Given this list of marker genes Dusp1, Jun, Hspa1a, Fos, Hspa1b, Fosb, Zfp36, here is a description of the gene set: from publication Cui A, Huang T, Li S, Ma A, Pérez JL, Sander C, Keskin DB, Wu CJ, Fraenkel E, Hacohen N (PMID 38057668) Cytokines mediate cell-cell communication in the immune system and represent important therapeutic targets. A myriad of studies have highlighted their central role in immune function, yet we lack a global view of the cellular responses of each immune cell type to each cytokine. To address this gap, the authors created the Immune Dictionary, a compendium of single-cell transcriptomic profiles of more than 17 immune cell types in response to each of 86 cytokines (>1,400 cytokine-cell type combinations) in mouse lymph nodes in vivo. A cytokine-centric view of the dictionary revealed that most cytokines induce highly cell-type-specific responses. For example, the inflammatory cytokine interleukin-1β induces distinct gene programmes in almost every cell type. A cell-type-centric view of the dictionary identified more than 66 cytokine-driven cellular polarization states across immune cell types, including previously uncharacterized states such as an interleukin-18-induced polyfunctional natural killer cell state. species: Mus musculus Genes negatively differentially expressed in cell type: cDC2 (conventional dendritic cell type 2) upon treatment with cytokine: IL-17B in mouse lymph nodes in vivo. Mouse Gene Set: CUI_CDC2_IL17B_RESPONSE_DN